Given this list of marker genes ACTB, CDH11, CDK13, ERCC2, TERT, MED25, SLC45A2, BAP1, DIS3L2, ERCC4, MYH3, RRAS2, KCNQ1, GTF2IRD2, ALK, OCA2, CHRNA7, CDK10 (NCBI Gene Id 8558), CDKN2B, KLLN, EIF4H, COL3A1, H19 (NCBI Gene Id 14955), PUS3, FOCAD, FGFR1, TERF2IP, CYP26C1, CDKN2A, MITF, DVL3, METTL27, POLR1A, SLC26A2, NEK9, THPO, ERCC3, FKBP10, TBL2, SMC3 (NCBI Gene Id 9126), AKT1, PTPN11, GNA11 (NCBI Gene Id 93626), XPC, XPA, SUFU, H1-4, RBM8A, STK11, ERF, RFC2, TP63, CDH3, PDE4D, RAF1, TSC2, CBL, SPTBN1, FBN1, IGF2, GTF2I, TASP1, MRAS, TRIM37 (NCBI Gene Id 4591), SLC25A24, MPL, ARL6IP6, HEPACAM, RBM28, DVL1, HEATR3, ERCC5, ROR2, EDEM3, SPTSSA, KCNQ1OT1, ZEB2, MC1R, HDAC8, RASA2, NCF1, PIK3CA, ASXL2, FRA10AC1, BAZ1B, CAMK2A, PDE11A, SDHB, TMEM270, PTCH1, TNFRSF11B, DDB2, COL7A1 (NCBI Gene Id 1294), HPS1, MSL3, MAD1L1, CHRNG, FGFR2, TSC1, SMO, USF3 (NCBI Gene Id 205717), LBR, FKBP6, CDK4, RRAS, PUF60, TNFRSF11A, STX1A, PCGF2, PTEN, RAD51, LIMK1, GTF2IRD1, RIT1, IFNG, TYR, NSDHL, H4C5, KRT14, DUT, POT1 (NCBI Gene Id 25913), PTCH2, NRAS, ACD, PRKAR1A, VPS37D, DNAJC30, BLOC1S5, CDKN1C, EZH2, TGFB3, SDHC, PIGH, ALX4, LZTR1, TYRP1, HRAS, SOS1, SETBP1, FZD2, SDHD, NFIX, EED, CLIP2, SOS2, WNT5A, LEMD3, SEC23B, BUD23, BRAF, CDC42, HEXB, ASXL1, NXN, FGFR3, ELN, GNAQ, PLP1, TAF4, SPRED2, SOX5, KRAS, SUZ12, MGMT, KANSL1, here is a description of the gene set: Nevus A nevus is a type of hamartoma that is a circumscribed stable malformation of the skin. Human Gene Set: HP_NEVUS studied in species Homo sapiens